The following is a description of a gene set: Mouse Gene Set: MIR_7070_5P Genes predicted to be targets of miRBase v22 microRNA mmu_miR_7070_5p in miRDB v6.0 with MirTarget v4 prediction scores > 80 (high confidence targets). species: Mus musculus from publication Chen Y, Wang X (PMID 31504780), and this is the list of marker genes: Nkd2, Sumo1, Aldh3a2, Klhdc8a, Limk1, Csf1, Foxp4, Tmem253, Grik3, Bgn, Mbnl3, Lsm11, Cep120, Gimap3, Zdhhc9, Srsf1, Tbx22, Grhl2, Xpr1, Caln1, Rnf214, Szrd1, Asgr1, Arap3, Nudcd3, Mras, Copz1, Acsbg2, Pak3, Cdip1 (NCBI Gene Id 72582), Lgalsl, Gnb1, Shank1, Cmklr1, Atp8b2, Btnl2, Mif4gd, Ypel1, Acsf2, Klrg2, Ccdc103, Nono, Ark2c, Mycbp, Samd4b, Fech, Ttc14 (tetratricopeptide repeat domain 14), Ang, Col1a1